The following is a description of a gene set: Reactome Pathway: Abasic sugar-phosphate removal via the single-nucleotide replacement pathway Abasic sugar phosphate removal via the single nucleotide replacement pathway requires displacement of DNA glycosylase by APEX1, APEX1-mediated endonucleolytic cleavage at the 5' side of the base free deoxyribose residue, recruitment of POLB to the AP site and excision of the abasic sugar phosphate (5'dRP) residue at the strand break. part of: Resolution of AP sites via the single-nucleotide replacement pathway species: Homo sapiens, and this is the list of marker genes: POLB, APEX1